Given this list of marker genes TUBA1B, TUBB1, TUBA3E, TUBA1C, DCTN1, TUBB2A, TUBA3C, TUBB8, TUBA3D, TUBA8, TUBA1A, TUBB3, TUBB2B, TUBB4B, TUBB6, TUBB, TUBB4A, TUBA4A, here is a description of the gene set: Pathway Definition from KEGG: DCTN1* // (TUBA+TUBB) Human Gene Set: KEGG_MEDICUS_VARIANT_MUTATION_CAUSED_ABERRANT_DCTN1_TO_RETROGRADE_AXONAL_TRANSPORT Mutation-caused aberrant DCTN1 to retrograde axonal transport. Pathway ID: N01158. Pathway type: Variant. Pathway class: nt06464 Amyotrophic lateral sclerosis. species: Homo sapiens